The following is a description of a gene set: The incorporation of four iron atoms and four sulfur atoms into an iron-sulfur cluster. Mouse Gene Set: GOBP_4FE_4S_CLUSTER_ASSEMBLY species: Mus musculus, and this is the list of marker genes: Iscu, Fxn, Lyrm4, Fdx2, Nfs1